Given this list of marker genes OTOP1, KCNJ2, here is a description of the gene set: Reactome Pathway: Sensory perception of sour taste The sour taste channel OTOP1 is located in type III taste bud cells where it transports H+ ions from the extracellular region into the cytosol. Organic acids such as acetic acid and citric acid are believed to also enter type III taste bud cells by passive diffusion of the protonated (uncharged) form of the acid across the plasma membrane. The increase in cytosolic H+ ions inhibits the KCNJ2 potassium channel and may also open unidentified sodium channels to further depolarize the cell. The resulting depolarization is adequate to generate an action potential which eventually results in release of the neurotransmitters serotonin (5-HT) and gamma-butyric acid (GABA) (inferred from mouse type III cells in Huang et al. 2005, Huang et al. 2009, Huang et al. 2011). Mice lacking both P2x2 and P2x3 ATP receptors do not produce nerve activity in response to sour tastants so ATP may play a role in transmission of sour taste. part of: Sensory perception of taste studied in species Homo sapiens